The following is a description of a gene set: This term refers to a phenotypic feature that was first observed prior to birth during the third trimester, which is defined as 28 weeks and zero days (28+0) of gestation and beyond. Third trimester onset studied in species Homo sapiens Human Gene Set: HP_THIRD_TRIMESTER_ONSET, and this is the list of marker genes: RRAGC, ESAM, PYCR1, RECQL4 (NCBI Gene Id 9401), BRD4, ASNS, DEPDC5, MRPS22, SHQ1, SNAP25, TNFRSF11A, MDFIC, NADK2, COASY, ADCY6, PLG (NCBI Gene Id 90749), ERF, SCN4A, CRLS1, RPL26, ALPK3, TRPV6, NDUFB11, ADGRG6, MPDZ, GINS1, BICD2, KMT2B, ZIC3, GBE1, ZMPSTE24, ALG1, GLDN, UBR1, NUP155, POMK, KMT2D, FZR1, SDHA, FANCB, CNTNAP1, PPP3CA, SOX18, SERPINH1, PRKAG2